Given this list of marker genes SLC2A1, PSMA8, SFN, TOP2A, KRT14, DSG3, SELENOI, DSC3, CDCA5, KRT5, NECTIN1, OSGEP, TPX2, here is a description of the gene set: from publication Inamura K, Fujiwara T, Hoshida Y, Isagawa T, Jones MH, Virtanen C, Shimane M, Satoh Y, Okumura S, Nakagawa K, Tsuchiya E, Ishikawa S, Aburatani H, Nomura H, Ishikawa Y (PMID 16007138) Human Gene Set: INAMURA_LUNG_CANCER_SCC_UP Up-regulated genes characteristic to the squamous cell carcinoma (SCC) type of non-small cell lung cancer (NSCLC). species: Homo sapiens Current clinical and histopathological criteria used to define lung squamous cell carcinomas (SCCs) are insufficient to predict clinical outcome. To make a clinically useful classification by gene expression profiling, we used a 40 386 element cDNA microarray to analyse 48 SCC, nine adenocarcinoma, and 30 normal lung samples. Initial analysis by hierarchical clustering (HC) allowed division of SCCs into two distinct subclasses. An additional independent round of HC induced a similar partition and consensus clustering with the non-negative matrix factorization approach indicated the robustness of this classification. Kaplan-Meier analysis with the log-rank test pointed to a nonsignificant difference in survival (P = 0.071), but the likelihood of survival to 6 years was significantly different between the two groups (40.5 vs 81.8%, P = 0.014, Z-test). Biological process categories characteristic for each subclass were identified statistically and upregulation of cell-proliferation-related genes was evident in the subclass with poor prognosis. In the subclass with better survival, genes involved in differentiated intracellular functions, such as the MAPKKK cascade, ceramide metabolism, or regulation of transcription, were upregulated. This work represents an important step toward the identification of clinically useful classification for lung SCC.